Given this list of marker genes CDH3, N6AMT1, SLC45A2, CYP1B1, CYP2W1, CYP2A7, AKR1C3, MC1R (NCBI Gene Id 4157), AKR1B10, CYP2A13, DCT, AKR1A1 (NCBI Gene Id 10327), ASIP, UGT1A10 (UDP glucuronosyltransferase family 1 member A10), CYP3A4, ARL1, AKR1C4, WNT5A, SLC24A5, ACMSD, BCL2, CYP2A6, LCAT, MFSD12, PMEL, CPT1A, UGT1A7, OCA2, UGT1A8, DDT, CYP3A5, GIPC1, RAPGEF2, RAB38, ATP7A, TYRP1, OPN3, CYP1A1, NFE2L2, FMO1 (NCBI Gene Id 2326), PRKCE, AKR7A3, AKR1B1, CBR4, FMO2, AKR7A2, TRPC1, TYR (tyrosinase), SULT1C4, SLC7A11, BDH2, CYP2D6, AS3MT, CITED1, APPL1, AKR1C2 (aldo-keto reductase family 1 member C2), CTNS, ZEB2, CYP1A2, AKR1C1, here is a description of the gene set: Human Gene Set: GOBP_SECONDARY_METABOLIC_PROCESS studied in species Homo sapiens The chemical reactions and pathways resulting in many of the chemical changes of compounds that are not necessarily required for growth and maintenance of cells, and are often unique to a taxon. In multicellular organisms secondary metabolism is generally carried out in specific cell types, and may be useful for the organism as a whole. In unicellular organisms, secondary metabolism is often used for the production of antibiotics or for the utilization and acquisition of unusual nutrients.